Given this list of marker genes CYP4F2, ADH4, ADH7, CYP4F3, ADH5, CYP4V2, here is a description of the gene set: A fatty acid oxidation process in which the methyl group at the end of the fatty acid molecule (the omega carbon) is first oxidized to a hydroxyl group, then to an oxo group, and finally to a carboxyl group. The long chain dicarboxylates derived from omega-oxidation then enter the beta-oxidation pathway for further degradation. Human Gene Set: GOBP_FATTY_ACID_OMEGA_OXIDATION studied in species Homo sapiens